Given this list of marker genes EPCAM, COL4A5, TNFAIP3, WAS, TINF2, SLC39A7, DUX4, IARS2, CARS1, GNAQ, IL10, NCF1, UROS, AEBP1, GJA1, ERAP1, HDAC8, TNFRSF13C, SLC39A4, NHP2, MAB21L1, WRAP53, GJB2, TNFRSF1A, CLTCL1, CD79B, APOE, ADAM17, NTRK1, ATOH7, MTTP, SF3B1, CAPN5, C4A, TRIM44, PARN, VPS33A, XIAP, COL17A1, CCR1, LRRC8A, ARPC1B, BLM, HLA-A, SEMA4D, TRAF3IP2, TERC, HLA-DRB1, ERCC8 (ERCC excision repair 8, CSA ubiquitin ligase complex subunit), NCF2, XPC, UBAC2, CRLF1, HLCS, IL12A-AS1, WIPF1, REV3L, LBR, ALOXE3, MST1, ZFX, PAX6, HLA-DPB1, ERF, RTEL1, IGHM (NCBI Gene Id 3507), IL6ST, NIPBL, ICOS, NPM1, CTLA4, STAT4, SMCHD1, BTD, NOD2, IL2RA, CD247, TBX4, DNASE1L3, ZEB1 (NCBI Gene Id 6935), ERCC4, IL36RN, ST14, ALOX12B, TKT, EXTL3, DNMT3B, FERMT1, DKC1, PIGN, NOP10, IL2RB, DUX4L1, LYZ, TBK1, RAG1, PIK3R1, PRTN3, ERCC6, LRBA, TLR4, STUB1, ERCC5, CTC1, MEFV, CST6, CD79A, ANKRD55, FGF10, GNA11, MBTPS2, PLXND1, SCN9A, XPA, SREBF1, STX11, TCF4, IFNGR1, SULT2B1, RAG2, LYN, CYSLTR2, CYBA, FOXC1, RNF125, UROD, FOXC2, BMP4, FGFR2, GMPPA, TCF3, PERCC1, PSMB8, GSN, SDR9C7, ABCA12, BLNK, BRD4, COL7A1, BTNL2, NCF4, IRF4, PLG, BCL10, KAT6A, TAF6, GATA1, SAMD9, FBN1, AP1B1 (NCBI Gene Id 162), DDB2, PLEC, IL23R, TARS1, TFRC, GPR35, AAAS, ERCC3, USB1, AARS1, RECQL, CYBB, RNF113A, CR2, BIRC3, HLA-DPA1, FOXP1, PTPN2, TP63, MPLKIP, EGFR, LACC1, FRG1, TERT, GNAS, BTK, STX16, BAP1, POLH, CASP10, ERCC2, IL6 (NCBI Gene Id 3569), HLA-B, TYMS, AIRE, CERS3, PNPLA1, PTPN22, SMC3, TGM1, COL4A6, NIPAL4, SPI1, IKBKG, CYBC1, RAD21, MIF, FASLG, CD27, GTF2H5, SMC1A, IL12A, ATP2A2, IGLL1, CD19, NLRP1, SLC35C1, ALDH3A2, NLRP3, CHD6, PAX1 (NCBI Gene Id 5075), IKZF1, PSMB4, FGFR3, MALT1, SLC29A3, KLRC4, TRAPPC11, PLCD1, MSMO1, ERCC1, GJB6, GTF2E2, AP1S3, FAS, TNFRSF13B, IGSF3, here is a description of the gene set: Human Gene Set: HP_INFLAMMATORY_ABNORMALITY_OF_THE_EYE studied in species Homo sapiens Inflammatory abnormality of the eye Inflammation of the eye, parts of the eye or the periorbital region.